Given this list of marker genes Ncstn, Psen1, Aph1a, Aph1b, Notch3, Psenen, Ybx1, here is a description of the gene set: species: Mus musculus Mouse Gene Set: REACTOME_NONCANONICAL_ACTIVATION_OF_NOTCH3 Noncanonical activation of NOTCH3